The following is a description of a gene set: Genes predicted to be targets of miRBase v22 microRNA hsa-miR-7108-3p in miRDB v6.0 with MirTarget v4 prediction scores > 80 (high confidence targets). studied in species Homo sapiens from publication Chen Y, Wang X (PMID 31504780) Human Gene Set: MIR7108_3P, and this is the list of marker genes: RGS3, GRIK4, HSPB8, SLC45A4, NTN1, WNT3A, EIF4G3, KIAA1755, ZNF589, ABHD8, SMG7, ISLR2, ARK2C (NCBI Gene Id 494470)